Given this list of marker genes TBL1XR1, UBAP2L, SPOP, GPC6, DOCK6, DGCR8, ZMYM2, DGCR2, DDX6, LARP7, FRA10AC1, B3GLCT, PIK3CA, RBMX, FAT4, KPTN (kaptin, actin binding protein), ARID2, TRMT1, RECQL4, FBXO11, CEP55, KIF26A, ADNP, TENM3, CTCF, MYCN, POLR3A, CDC42BPB, TBX1, GATAD2B, SRCAP (Snf2 related CREBBP activator protein), CACNA1G, ADAMTSL2, RPL10, SLC6A17, HSPG2, TAF4, RTL1, EFEMP2, FOXL2, EBP, KCTD1, PDE4D, KMT2A, DLK1, B9D2, RFX7, DDR2, KDM4B, MED13, PYCR1, PCGF2, RNU4-2, BICRA, DNMT3A, HDAC4, DGCR6, TRIP12, GABRA3, INTS1 (integrator complex subunit 1), SMAD4, EDEM3, PHF6, MAPKAPK5, AHDC1, TBX15, MAPK8IP3, MEG3, DHX9, PCNT, WDR35, SMARCA2, ESS2, SPEN, PGM3, here is a description of the gene set: Narrow palpebral fissure Reduction in the vertical distance between the upper and lower eyelids. studied in species Homo sapiens Human Gene Set: HP_NARROW_PALPEBRAL_FISSURE